The following is a description of a gene set: Mouse Gene Set: chr12B3 studied in species Mus musculus, and this is the list of marker genes: Gm1818, Stxbp6, Hectd1, Gm2089, Ap4s1, Gm7481, Gm40418, Gm22663, Scfd1, Gm24731, G2e3, 3110039M20Rik, Gm9921, Gm19599, 1700008C04Rik, Gm34304, Gm46327, Gm18503, Gm33869, Foxg1, Gm7476, 1810007C17Rik, Gm18112, Gm7172, Gm18623, Coch, Gm33680, Gm7456, Gm40421, Gm19309, Strn3 (NCBI Gene Id 94186), Gm15901, Gm24948, Gm7392 (NCBI Gene Id 676684), Gm29818, B230217J21Rik (RIKEN cDNA B230217J21 gene), Rps11-ps4, Gm25015, Gm7422, Prkd1, Nova1